Given this list of marker genes RNU5F-1, PRPF3, SNRPB (NCBI Gene Id 6628), SNRPD3, U2SURP, SNRNP27, DDX39B, RNVU1-15, SF3B6, SLU7, RNVU1-14, SNRNP70, PPIH, SNRPB2, ARFGEF1, RNU6-7, LUC7L2, LSM10, RNVU1-6, SNRPC, SNRNP40, LSM11, LSM6, PRPF8 (pre-mRNA processing factor 8), RNVU1-2A, LSM7, SNRPN, LUC7L3, DDX46, TXNL4A, RNVU1-19, SNRPA, SF3A1, RNU5E-1, SART1, GEMIN4, PRPF4, RBM42, CD2BP2, RNVU1-3, TSSC4, PRPF31, RNVU1-4, SNRPF, RNVU1-17, EFTUD2, PRPF40A, SF3B3, RNU2-1, SNIP1, RNVU1-1, RNU4-2, LSM2, LUC7L, SNRPG, ZMAT2, BUD13, TAF12-DT, USP39, RNU6-1 (RNA, U6 small nuclear 1), SF3A2, LARP7, DDX23, TXNL4B (NCBI Gene Id 54957), SNRPA1, SNRPGP15, RNVU1-8, SNRPD2, SF3B2, TGS1, LSM5, SNRPE, RNU5A-1, RNU6ATAC, SF3B5, SNRNP200, RNU4ATAC, RBMX2, SF3B4, RNU11, PRPF18, RNU6-9, LSM3, HEXIM1, HTATSF1, RNU5D-1, SNU13, LSM4, PHF5A, PRPF40B, MEPCE, SF3B1, RNU1-4, RN7SK, AAR2 (AAR2 splicing factor), SART3, RNU4-1, WEE2-AS1, SF3A3, RNVU1-7, PRPF39, RNU5B-1, LSM8, PRPF6, SNRPD1, here is a description of the gene set: Human Gene Set: GOCC_SMALL_NUCLEAR_RIBONUCLEOPROTEIN_COMPLEX species: Homo sapiens A ribonucleoprotein complex that contains at least one RNA of the small nuclear RNA (snRNA) class and as well as its associated proteins. These are typically named after the snRNA(s) they contain, e.g. U1 snRNP, U4/U6 snRNP, or 7SK snRNP. Many, of these complexes become part of the spliceosome involved in splicing of nuclear mRNAs. Others are involved in regulation of transcription elongation or 3'-end processing of replication-dependent histone pre-mRNAs.